Given this list of marker genes PEX1, ERCC3, ERCC5, SLC35C1, UBE3A, ATRX, MECP2, SUCLA2, KAT6B, MTRR, XPC, RAB3GAP2, SLC16A2, AP4M1, ACOX1, TCF4, SNRPN, KCNH1, ERCC2 (ERCC excision repair 2, TFIIH core complex helicase subunit), AIFM1, NDP (norrin cystine knot growth factor NDP), CTSD, SLC9A6, XPA, NDE1, B3GLCT, L2HGDH, GCH1, ERCC4, ARX, DMPK (DM1 protein kinase), NKX2-5, WDR81, DDB2, TONSL, PTS, SNAP29 (synaptosome associated protein 29), TK2, TSHB, here is a description of the gene set: species: Homo sapiens Human Gene Set: HP_INTELLECTUAL_DISABILITY_PROGRESSIVE Intellectual disability, progressive The term progressive intellectual disability should be used if intelligence decreases/deteriorates over time.